Given this list of marker genes ACY3, FREM2, L2HGDH, METTL18, MLYCD, TOR1AIP2, PEG3, MEST, LEPR, POLA2, RNF7, ETFB, TMEM38B, CHRDL1, MYH11, FN3K, ARPP21, PRSS12, EYA1, ELP6, CCNK, CES1, TNRC6C, EMC9, NMNAT2, PROCA1, CFAP96, UNC13B, FOXO4, CLDN5, NT5DC3 (NCBI Gene Id 51559), PPARG, GPC3, ANKH, MYOM2, AATK, LDB2, SLC38A4, MYL3, DNAJC28, SIK2, ARHGAP19, SSH2, ZFP91, CACNA1H, EPB41L4B, MTMR3, TTC9 (NCBI Gene Id 23508), GPR135, PTGIS, USHBP1, IVD, DTNA, ZDHHC23, GUCY1B1, HLCS, NEURL1 (NCBI Gene Id 9148), ERCC6L2, TF, LBX1, PLIN5, DIXDC1, AMY2A, PCMTD2, MMD, TSNAX, FBXO2, TAL2, MPZ, TTC1, ANKRD2, HSPA12B, BCL2, LDHB, SNHG8, CHST7, ANP32A, SPTBN1, MYLK, WDR86, NREP, PLAAT1, MYL10, FLNC, ARMH4, P2RY2, SLC1A1, WFDC1 (NCBI Gene Id 58189), FXYD6, KLHL8, KCNA7, AUTS2, ARHGAP20, GPD2, KANK1, SPARCL1, AR, SEMA6D, KCNH2, CTF1, ZBTB20, ANGPTL7, NPNT, KCNA5, LPL, MLXIPL, HCAR1, SCRN1, FABP4, PABPC4, LIMK2, ST3GAL6, FOXD3, C11orf52, SLC35G1, TIGAR, HOOK1, GSN, GALNT15, TXNIP, MPZL1 (myelin protein zero like 1), CD200, ATP9A, ADHFE1, NPR2 (natriuretic peptide receptor 2), BEND7, SHROOM4, KIT, MAP1B, RHOT2, ADIPOQ, DLX5, SMTN, FHIP1A, SMAD3, TEAD1, CA14, CCDC136, CHDH, PACSIN3, CHST1, PRCD, TNFRSF11B, TMEM201, CXCL14, TRARG1, CDON, COQ10A, S1PR5, ZFP82 (ZFP82 zinc finger protein), SLC22A3, ANGPT1, CMKLR2, HAGH, BCCIP, CDC42EP1, BAMBI, REM1, AHCY, PDE2A, MYL9, SLC25A3, C1orf21, KYAT3, SPRYD4, POPDC2, VSIG4 (V-set and immunoglobulin domain containing 4), KRBA1, NQO1, SCN3B, NRN1, EXOC6, PLLP, CLIC5, SNCAIP, CPEB1-AS1, UQCRC1, IPP, AKAP12, KCNQ4, LRRC3B, FAH, LIMS2, OAZ1, MTFP1, ANK1, SCARA3, SEMA3A, ZDHHC17, TMIGD1, SMCO3 (NCBI Gene Id 440087), ALDH1A3, RAPSN, COL22A1 (NCBI Gene Id 256626), BVES, WNT4 (Wnt family member 4), HOXA5, LYPD6 (LY6/PLAUR domain containing 6), GDF10, IMMT, here is a description of the gene set: Genes down-regulated in macrophages: wildtype versus MYD88 knockout. Human Gene Set: GSE22935_WT_VS_MYD88_KO_MACROPHAGE_DN studied in species Homo sapiens from publication Qualls JE, Neale G, Smith AM, Koo MS, DeFreitas AA, Zhang H, Kaplan G, Watowich SS, Murray PJ (PMID 20716764) Nitric oxide (NO) produced by macrophages (MØs) is toxic to both host tissues and invading pathogens and its regulation is therefore essential to suppress host cytotoxicity. MØ arginase 1 (Arg1) inhibits NO production by competing with NO synthases for arginine, the common substrate of NO synthases and arginases. Two signal transduction pathways control Arg1 expression in MØs. First, a MyD88-dependent pathway induces Arg1 in intracellular infections, while a second Stat6-dependent pathway is required for Arg1 expression in alternativelyactivated MØs. We found that mycobacteria-infected MØs produce soluble factors that induce Arg1 in an autocrine-paracrine manner via Stat3. We identify these factors as IL-6, IL-10 and GCSF. We further establish that Arg1 expression is controlled by the MyD88-dependent production of IL-6, IL-10 and G-CSF rather than cell intrinsic MyD88 signaling to Arg1. Our data reveal the MyD88-dependent pathway of Arg1induction following BCG infection requires Stat3 activation and may result in the development of an immunosuppressive niche in granulomas due to the induced Arg1 production in surrounding uninfected MØs